The following is a description of a gene set: Human Gene Set: GSE21670_TGFB_VS_IL6_TREATED_CD4_TCELL_DN Genes down-regulated in CD4 T cells: TGF beta versus IL6. STAT3, an essential transcription factor with pleiotropic functions, plays critical roles in the pathogenesis of autoimmunity. Despite recent data linking STAT3 with inflammatory bowel disease, exactly how it contributes to chronic intestinal inflammation is not known. Using a T cell transfer model of colitis we found that STAT3 expression in T cells was essential for the induction of both colitis and systemic inflammation. STAT3 was critical in modulating the balance of T helper 17 (Th17) and regulatory T (Treg) cells, as well as in promoting CD4+ T cell proliferation. We used chromatin immunoprecipitation and massive parallel sequencing (ChIP-Seq) to define the genome-wide targets of STAT3 in CD4+ T cells. We found that STAT3 bound to multiple genes involved in Th17 cell differentiation, cell activation, proliferation and survival, regulating both expression and epigenetic modifications. Thus, STAT3 orchestrates multiple critical aspects of T cell function in inflammation and homeostasis. species: Homo sapiens from publication Durant L, Watford WT, Ramos HL, Laurence A, Vahedi G, Wei L, Takahashi H, Sun HW, Kanno Y, Powrie F, O'Shea JJ (PMID 20493732), and this is the list of marker genes: CCDC160, FILIP1, WDR3, SLC25A35, WNK3, DNAJC21 (NCBI Gene Id 134218), NOC4L, LCOR, SLC5A5, CEP290, STAM, SPACA3 (NCBI Gene Id 94024), CASP7, FAM76A, FRMPD2, MAPK8, YTHDF2, TSPYL1, ROGDI, NEK6, C11orf54, FGF11, ELOVL2, ESRRB, PSMA4, MALSU1, PLCB1, RANBP6, HOXA7, SCNN1B, DIP2C, EML2, NGFR (NCBI Gene Id 4804), SLC35B1, TMED6, BORCS8, AMBN, MORC3, DLST, RAB39A, TH, TSR2, CSNK1G3, RSPO3, RGS6 (regulator of G protein signaling 6), QRICH1, FGD1, SLC24A2, TCTN3 (tectonic family member 3), F3, GRID2, PSMC6, USP6NL, LDOC1, IFT46, TNFAIP6, ACBD7, MORN2, ITGA10, SUCLG1, RLF, SCO1, SARM1, SENP1, ROM1, THSD7A, EMC4, MED6, HORMAD2, COMMD6, TNFRSF13B, B4GALT1, PEMT, L1TD1, CATSPER2, PPP2R5E, GATA4, KHDC3L, NSMCE3, CNPY3 (NCBI Gene Id 10695), DCTN3, POLR2I, CCDC12, APRT, BRINP1, WDR64, PPP4R3A, MLX, POLR2K, GSPT2, CRIPT, ALDH1A3, ZMAT1, LGI2, CAMK1D, DDX42, KIF5B, AJAP1, XRN1, ENSA, GNL3, DCAF1, ZNF266, MIER3, RMDN3, DHRS7 (NCBI Gene Id 51635), SH2D6, GPR88, SNORC, KIAA0753, FGF23, TST, KPLCE, NFIX, XPNPEP1, TRAPPC4, SURF2, MRPS18B, CYP27A1, LAMP2, YIPF5, TOP3A, VTI1A, FAIM, TRMT6, TBRG4 (NCBI Gene Id 9238), MEAK7, FAM181A, SCFD1, HEMK1, PLEKHO1, G0S2, MYH6, ASGR1, CRPPA, SPAM1, CUL2, TJAP1, COMMD9, MAGEB5, PPP1R11, LGALSL, EXOSC4, DNAJC10, SLC25A34 (solute carrier family 25 member 34), LY6D, TMEM139, OTUB1, C9orf78, SLC1A1, MRPS9, PNO1, MYO1B, TMX3, COPS7B, TXNL4A, TREH, CCDC159, ALDH6A1, VCF1, PKDREJ (polycystin family receptor for egg jelly), PPA1, LAMB2, TNFRSF11B, CEP250, PRAMEF12, LRRC52, SP2, FLT3LG, GIN1, BCL11A, PLVAP, CFAP418, IQCF1, CNNM2, KRTDAP, KATNA1, POLR1G, BYSL, UFM1, TESK2, YME1L1, MSRB2, TMEM168 (NCBI Gene Id 64418), HS2ST1, ZCCHC9, ADPRS, MYLK3, MINPP1, BRD9, ADAM17, DIABLO, CNOT11 (NCBI Gene Id 55571), AGPAT2, CCDC115, ARPC4, KLHL30, CSPG5, LRRC38 (NCBI Gene Id 126755), ABCC8